The following is a description of a gene set: Binding to ceramide 1-phosphate. Human Gene Set: GOMF_CERAMIDE_1_PHOSPHATE_BINDING studied in species Homo sapiens, and this is the list of marker genes: PLA2G4A, CPTP, PLEKHA8P1, GLTP, PLEKHA8, GLTPD2, CERT1